The following is a description of a gene set: Any process that stops, prevents, or reduces the frequency, rate or extent of an organismal process, the processes pertinent to the function of an organism above the cellular level; includes the integrated processes of tissues and organs. Mouse Gene Set: GOBP_NEGATIVE_REGULATION_OF_MULTICELLULAR_ORGANISMAL_PROCESS species: Mus musculus, and this is the list of marker genes: Il2ra, Wnt7b, Hdac7, Furin (NCBI Gene Id 78149), Ptpn13, Pik3cb, Tfpi, Nol3, Rufy3, Rnf6, Cyp51, Adamts7, Pgam5, Tnnt1 (troponin T1, skeletal, slow), Cebpb, Abr, Hif1a, Gpr37l1, Fbln5, Fas, Actr3, Cxcl10, D130043K22Rik, Tnfaip8l2, Gp1ba, Tac1, Scgb1a1, Vash1, Gsk3a, Oprm1, Serpine2, Arg2, Adam17, Mt3, Sema4f, Nodal, Arg1, Ptgds, Tusc2, Hgs, Lilra5, Zfp423, Alms1, Hmox1, Pros1, Fgf23, Socs5, Cdh3, Nkx3-2, Mir7-1, Gpr68, Zc3h12a, Gpr55, Ltbp3 (latent transforming growth factor beta binding protein 3), Trp53, Sox11, Vtn, Hmga2, Zfp35, Tspan32, P2ry2, Inha, Dnajb11, Tek, Gpatch3 (G patch domain containing 3), Sri, Tspan8, Zfpm2, Tnfrsf13b, Cav3, Scrib, Col4a3, Apoa1, Flcn, Wnt4, Srf, Ptprc, Il20rb, Gper1, Ildr2, Reg3g, Cblb, Dip2b, Tmem98, Anxa4 (annexin A4), Prnp, Rbx1-ps, Rnf125, Prkg1, Cd276, Lilrb4b, H2-M3, Marchf7, Dab1, Il1b, Suz12, Pglyrp3, Fig4, Hdac2, Rela, Stab1, Pak1, Flt3, Cdkn2a, Hdac5, Ctla4, Jak3, Crebbp, F2rl1, Nfib, Angpt4, Extl3, Cd84, Rc3h2, Fgr, Nova1, Ctnna1, Bmp7, Fgfr3, Thy1, Ppp3ca, Nutf2-ps1, Pde3b, Ptger3, Sod1, Ager (NCBI Gene Id 11596), Cd200r1 (CD200 receptor 1), Smurf1, Psg23 (pregnancy-specific beta-1-glycoprotein 23), Tlr4, Ankrd26, Adcy7, Yy1, Irgm2, Zfp36 (zinc finger protein 36), Pdgfb, Cd59a, Ptprs, Cd300a, Fgfr1, Atg12, Kremen2, Nme2, Id2, Fbln1, Hmgb3, Met, Dact3, Ovol2, Tmem176a, Gpr174, Pglyrp2 (peptidoglycan recognition protein 2), Crhbp, Ctsc, Kcnk2, Adm, Synj2bp (synaptojanin 2 binding protein), Hoxc10 (NCBI Gene Id 209448), Nr1h2, Tnmd, Igfbp5, Lif, Wnt7a, Men1, Slamf8, Il22ra1, Cyba, Laptm5, Enpp3, Rest, Nod2, Homer3, Spx, Col4a2, Spart, Ccn4, Brca2, Enpp1, Ufd1, Xcl1, Cx3cl1, Adamts12, Thbs2, Rabgef1, Il13, Pla2g3, Spred3, Actn3 (actinin alpha 3), Arhgap4, Arrdc3, Ezr, Efemp1, Mag, Abhd6, Vsig4, Dlg5, Anxa1, Sh2b3, C5ar2, Cacnb3, Sinhcaf, Gja1, Il4, Atg5, Ezh2, Tle3, Ffar4, Stk4, Fgl2, Cd24a, Crhr2, Arrb2, Sema6a, Prdx4, Cd160, Oga, Aldh1a1, Ing1, Dbn1, Foxo1, Appl2, Tnfsf4, Bin1, Plaur, Rhbdd3, Foxc2, Anxa2, S2bpcox16, Mad1l1 (NCBI Gene Id 17120), Pth, Avp, Wnt3, C1qtnf1, Dock7 (NCBI Gene Id 67299), Rbpj, Spinkl, Akap1, Syt4, Bmpr1a, Tsc2, Jam2, Trim46, Egfr (epidermal growth factor receptor), Gpr137, Fgb, Rab11fip5, G6pdx, Zfp418, Il4i1, Trpv1, Dspp, Igf1, Hrg (histidine-rich glycoprotein), Hfe, Pthlh, Sox10, Erbb2, Proc, Tifab, Amot, Cptp, Gpr149, Pla2g2a (phospholipase A2, group IIA (platelets, synovial fluid)), Rian, Parp3, Hdac9, Aida, Adamts5, Il33, Il12b, Clec4a3, Mcc, Pax6, Wnt3a, Abcd1 (NCBI Gene Id 11666), Apoc1, Glra1, Nr1d1, Cyp19a1, Trpc2, Bglap2, Spi1, Syngap1, Oas1d, Gstp3, Lgmn, Rnls, Krit1, Sap30l, Cd86, Tgfb1, Hdac6, Apoc3, Cck, Vtcn1, Ntrk3, Ccr5, App, Il17rd, Hgf, Frzb, Ogt, Foxe3, Adora2a, Myc, Wnt11, Prickle1, Cxcr3, Gstp1, Usp2, Luc7l (NCBI Gene Id 72300), Srgn, Pik3r1, Mir98, Kcnk9, Pdcd4, Pi16, Elane, Agtr2, Zfp354c, Tnf, Klf2, Havcr2 (NCBI Gene Id 268402), Mbd1, Gata3, Ctdsp1, Gja5, Cygb, Naxe, Bmal1, Ccr1, Apln, Ddit3, Dynlt1b, Rbbp4, Lrrc32, Bcl6, Eaf2, Plcl1 (NCBI Gene Id 227120), Fgf3, Gpr35, Btg2, Parp1, Gata1, Stk11, Samsn1, Il10, Abcc8, Atp2a1, Retn, Itch, Insr, Cd38, Daam2, Mc4r, Gpr4, Nrdc, Tpsab1, Tgfbr1 (transforming growth factor, beta receptor I), Btla, Runx3, Dll1, Grem1 (gremlin 1, DAN family BMP antagonist), Wwc2, Brms1, Clec4a4, Lhx2, Chrm3, Pdcd1lg2, Hamp2 (NCBI Gene Id 66438), Npvf, Nlrc3, Cftr, Cst7, Ccr7, Nppa, Sin3a, Ifngr1, Hpgds, Dkk4, Gtf2i, Rock2, Ptpn23, Oas1h, Slc4a2, Dkk1, Hes1, Nrp1, Cbln1, Atxn2, Ins2, Traf3ip1, Hspb1, Prkca, Gbp4 (guanylate binding protein 4), Tgfb2, Sox6, Cysltr2, Mkx, Sfrp2, Epn1, Mtor, Tnfrsf4, Macir (macrophage immunometabolism regulator), Coro1c, Thoc5, Morc3, Bmp4, Arhgdib, Gpnmb, Sfmbt1, Tia1, Sdhaf2, Gnrh1, Elf4, Bmpr2, Ptprr, Lef1, Pglyrp4, Atp1a2, Ptpn11 (NCBI Gene Id 72646), Serpinb1a, Vsx2, Slc2a10, Gpr137b, Il15, Dlx1, Mycn, Nfkbid, Arid4b, Nploc4, Fstl4, Banf1, Trp63, Evl, Inpp4b, Lpin1, Tlr6, Selenos, Sox15, P2rx4, Gas6, Ticam2, Mecp2, Cntf, Snai2, Gjd3, Atp2b4, Sparc, Sirpa, Klkb1, Slc11a1, Atoh1, Fam76b, Sema4a, Tie1, Lst1, Arhgap42, Pias3, Nfkb1, Dab2ip, Slit1, Hmgb1, Adipoq, Rapgef2, Serpine1, Socs2, Nf1, Rarg, Kat5, Rarb, Tmx1, Sars1, Agt, Slamf1, Foxp4, Acp5 (NCBI Gene Id 11433), Ttr, Khsrp, Arrb1, Cers2, Crtam, Adgrb2, Grk2, Epha4, Ptk2, Siglec1 (NCBI Gene Id 20612), Pou4f2, Slfn1, Inpp5d, Nkx3-1, Cd96, Ywhah, Cx3cr1, Pdgfa, Bglap, Cldn18 (claudin 18), Nmu, Esp22, F2r (coagulation factor II thrombin receptor), Uts2r, Ada, Arhgef2, Pdcd1, Gata6, Tgfb3, Ttc3 (NCBI Gene Id 70444), Rps6ka6, Ccn6, Ihh, Trib2, Ccn3, Nrarp (NCBI Gene Id 67122), Rflnb, Prl7d1, Pax8 (paired box 8), Hmgcr, Pira1, Oas1g, Bcl11a, Tob2, Nr2e1, Lrfn5, Cxadr, Vegfa, Fbxw7 (F-box and WD-40 domain protein 7), Ryk, Nmi, Lax1, Fbn1, Isx, Zbtb7b, Pag1, Calca, C1qc (complement component 1, q subcomponent, C chain), Cd2ap, Tgfbr2, Gucy1a1, Idh2, Zc3h12d, Il23a, Otud5, Lrpap1, Sdc4, H2-T23, Epha7, Fga, Lyn, Stard13, Oprk1, Map2k5, Bcl2, Oas1c, Ppm1b, C1qtnf3, Fkbp1b, Nog, Atf2, Prkcd, Thbd, Fgl1, Abcg8, Il36rn, Tph1, Zfp683, Lingo1, Hes5, Adamts1, Tarm1 (NCBI Gene Id 245126), Prox1, Pde4d, Casz1, Ggcx, Tff2, Acvr1b, Mapkbp1, Gpr39, Id4, Prdx2, Mertk, Dll3, Klf7 (Kruppel-like transcription factor 7 (ubiquitous)), Adamts9, H2-Aa, Epn2, Slc6a4, Chsy1, Lnpep, Angpt1, Nlrp6, Tnfrsf11b, Chid1, Dtx1, Srsf6, Usp19, Ccnd2, Dusp3, Rgs2, Gstp2, Ucn2, Fgf13, Stc2, Drd2, Adtrp, Il1rl1, Plxna3, Trib1, Rac1, Drd1, Gata2, Vsir, Ppara, Rel, Ifrd1, Erfe, Tcf4, Slit2, Optc (NCBI Gene Id 269120), Adra1a, Dsg2, Klhl22, Nmnat1, Src, Nmb, Adgrb3, Dock4, Adamts18, Apoh, Akap8, Jarid2, Bcor, Ubash3b, Prkar1a, Tnr, Axl, Irgm1, Fto, Bmp10, Tbx5, Ulk1, Rara, Stat3, Runx1, Nr5a2, Clec2i, Tsku (NCBI Gene Id 244152), Gba1, Wwc1, Rgs4, Cry1, Zfpm1, Cdkn2b, Ndfip1, Tnfaip6, Nmbr, Kng2, Acvr2b, Rai1 (NCBI Gene Id 19377), Gp5, Ilrun, Npff, Loxl3, Pla2g5 (NCBI Gene Id 18784), Klf4, Ddx56, Clec4g, Plat, Ufl1, Hcrt, Ptgdr2, Clstn3, Sap130 (Sin3A associated protein), Cntnap2, Pparg, Tacstd2, Ifng, Pira12 (paired-Ig-like receptor A12), Kdm1a, Hdac1, Il12a, Sema3g, Socs1, Nlrp12, Spred2, Efna3, Pctp, Wdr77, Ccr2, Gnas, Shc1, Prdm16, Spry1 (sprouty RTK signaling antagonist 1), Socs6, Otud7b, Foxp1, Fgg, Ypel4, Nfe2, Rock1, Ecm1, Gsdma3, Cidea, Ssc5d, Ptprm (protein tyrosine phosphatase receptor type M), Alox12, Bbs2, Inhbb, Angpt2, Spsb3, Cpb2, Rgma, Cd37 (NCBI Gene Id 12493), Dpysl5, Qki, Smad4, Il4ra, Gal, Acvr1c, Nova2, Rspo2, Trem2, Ccr1l1, Suds3, Nras (NCBI Gene Id 99853), Sorl1, Milr1, Aqp4, Calcr, Napepld, Tmem119, Wnt10b, Mapk11, Stc1 (stanniocalcin 1), Clnk, Ahsg, Shh, Nlrp3, Peli1, Trak2, Nkx6-1, Adgrb1, Pla2g2f, Lgr4, Ldlrad4, Mir1a-2, Sema3a, Ski, Abcd2, Tnfaip3, Gfra4, Nos3, Cdkn1b, Kcnma1, Foxj2 (forkhead box J2), Ctnnb1, Inhba, Hhex, Rad21, Tbx21, Hhip, Vdr, Hey2, Tert (telomerase reverse transcriptase), Il18r1, Fbxo11, Kremen1, Emilin1, Mlip, Stat1, Kcnc4, Oas1f, Ripor2, Apod, Apoc2 (apolipoprotein C2), Git1 (GIT ArfGAP 1), Pdgfra, Oas1b, Ptpro, Cd9, Rc3h1, Il17d, Dcn, Sav1, Mefv, Ceacam2, Jak2, Tsc22d1, Mc1r, Sftpd, Xaf1, Wnt9b, Sox9, Vgll4, Hlx, Wnk1, Rap1gap, Yjefn3, Hspa9 (NCBI Gene Id 23909), Fbxo32, Nr1h3, Dhx58, Itgb1, Il1r2, Nckap1l, Il23r, Errfi1 (ERBB receptor feedback inhibitor 1), Cryba1, Vasn, Ido1, Foxp3, H19, Ctdp1, Kat8, Adra1d (adrenergic receptor, alpha 1d), Tnfrsf10b, Dicer1, Tlr2, Irak3, B2m, Gorasp1, Fer, Ngfr (NCBI Gene Id 18053), Spn, Efna1, Wnt9a, Calr, Pglyrp1, Lgals9, Rnf128, Il17f, Itga4, Pgk1 (NCBI Gene Id 214853), Sh2d1b1, Tafa3, Tspo, Pde5a, Sema6c, Map2k6, Gclc, Dusp22, Kctd11, Atp2b1, Pf4, Sema5a, Clec2g, Slc37a4, Prtg, Oas1a, Spag11a, Cnr1, Tnfrsf1a, Smad3 (SMAD family member 3), Muc16 (NCBI Gene Id 73732), Usf3, Tgfbr3, Tlr8, Apoa2, Prg2, Ngp, Gdf1, Bcl3, Tcf7l2 (NCBI Gene Id 21416), Atg9a, Slc12a2, Abcg5, Hsf1, F12, Esr2, Elapor2, Nos1, Ptprg, Ephb2, Hook3, Cd74, Nr5a1, Ism1, Gimap5, Fyn, Bmyc, Pten, Etv4, Foxa1 (forkhead box A1), Ulk2, Ldlr, Cyp27b1, Plcl2, Bank1, Serpinb1b, Adrb1, Spry2, Casp3, Mad2l2, Ucn, Tet1, Spink7, Homer2, Fxr1, Kifap3, Rbx1, Adora1, E2f2, Chrnb2, Minar1, Cit, Tigit, Nkx2-1, Nkx6-2 (NCBI Gene Id 14912), Gstp-ps, Adrb2, Fermt1, Tmem178, Trpm4, Smad2, Ing2, Id1, Crh, Sulf1, Apoa4, Il27ra, Chadl, Irf1, Dusp10, Rgn, Ctsg, Plac8, N4bp1, Laptm4b, Cul3, Ins1, Pcsk9, Sema6d, Trpc6, Myocd, Dlx2, Trpv3, Cdk6, Tafa5, Cuedc2, Lepr, Nlrx1, Ccl2, Procr, Nutf2, Mafb, Gata5 (NCBI Gene Id 228988), Neurog1, Hoxa7, Tnfrsf14, Pitx3, Hnf1b, Cnmd, Stk39, Smad7, Serping1, Notch1, Fuz, Tbc1d10c, Spred1, Adipor1, Sema3e, Nfatc4, Mbp, Pla2g2d, Ctsk, Trpc5, Bmp2, Cited2, Adcy10, Nr1h4, Arid4a, Igtp, Flt1, Alpk2, Nrg1, Ptgs2, Rtn4r, Fcgr2b, Sfrp1 (secreted frizzled-related protein 1), Cd274, Rheb, Abcg2, Nav3, Smad6, Il6, Apc, Gli3, Creb3l1, Prg4 (NCBI Gene Id 96875), Mtmr2, Mill1, Rag2, Npsr1, Cga, Dlk1, Mir301, Ahr, Cdh1 (NCBI Gene Id 12550), Sct, Ltf, Il22, Alox5, Rtn4, Tyro3, Lep, Bst2, Tyrobp, Vax1, Traip, Msx2, Clec2d, Ghrl, Pibf1, Cmklr1, Cd44, Fzd7, Zfp750, Crhr1 (corticotropin releasing hormone receptor 1), Ptn, Foxo4, Tac4, Ghsr, Hdac3, Serpinb1c, Osr1, Kdm4a, Ip6k1, Gdf5, Cldn5, Gdf10, Lama4, Timp1, Tmem176b, Peli3, Acot13, Lrp4, Cd200, Grn, Pilrb1, Sost, Tmprss6, Lin28a (lin-28 homolog A), Zc3h8, Zfp706, Dusp5, Phf14, C1qbp, Npy2r, Tjp2, Rps19, Rhoa, Gdi1, Hnrnpk, Twist2, Cd80, Cpe, Idua, Hamp (NCBI Gene Id 84506), Tmem131l, Nptn, Cdkl3, Tacr2, Angptl7, Ago1, F2, Fn1, Frs2, Plg, Ndrg2, Wt1, Sptbn4, Il19, Pkn1 (protein kinase N1), Lgals1, Pfn2, Mdk, Zfas1, Pml, Clec4a2, Marveld3, Efnb3, Rab11fip3, Ttc21b, Atp2a2, Foxc1, Rassf5, Fstl3, Pomc, Fshr, Rab11fip1, Pax2, Plk2, Mef2c, Oas3, Calcrl, Apom, Cartpt, Trim11, Plau, Syt11, Adra2a, Drd3, Atp1a1, Avpr1a, Adra2c, Cd36, Itga9, Tomm70a, Cactin, Tnfrsf1b, Ifnb1, Ppp1r11, Trim63, Tnfrsf21, Bcr, Adcyap1, Tfe3, Svep1, Anxa5, Apcs, Brms1l, Btk, Dock5, Ptk2b, Glmn, Lgals3, Gsk3b, Rgcc, Gli2, Sox8, Tmem53, Rnf10, Rflna (NCBI Gene Id 73121), Adgrf5, Cdk5, Erbin, Thbs4, Asmt, Npr3, Tlx2, Trim30a, Acod1, Atf4, Trh, Oas1e, Rbp4, Reg3a, Ptger4, Ybx3, Phb2, Wnk4, Mstn, Mylip, Csk, Uts2, Thbs1, Relb, Cd69, Nme1, Clec12a, Apoe, Sap30, Atm, Ntn1, Fgf8, Ptpn6, Lilrb4a, Smo, Gbp7, Irag1, Kng1, Kcnn4, Adora2b, Foxj1, Iapp, Rbbp7, Adrb3, Glrx3, Ubr5, Atf5, Rb1, Eif2ak3, G6pd2, Mmp2, Tcta, Btn2a2, Ppp2ca, Hs3st5, Sema3f, Ptpn2, Ascl2, Ccl3, Cry2, Sigirr, Apoc2l, Cul4a, Mtnr1b, Fasl, Gimap3, Mir329, Mul1, Hpn, Epha2 (Eph receptor A2), Ptch1, Ecscr, Twsg1, Mdga1, Pln, P2rx7, Lrrc17, Cebpa, Cst3, Bpi, Pawr, Cd34, Rbm10, Trim62 (NCBI Gene Id 67525), Twist1, F11, Zbtb46, Il2, Fgfr4, Lag3, Nf2, Ccl11, Acot11, Map2, Mark1, Brinp1, Ptpn22, Cnr2, Hoxa5, Stub1, Fbxo7, Zfp608, Sirt2, Cd63, Serpinf2, Psen1, Sirt1, Mfn2 (mitofusin 2), Bdnf, Wnt5a, Gata4, Trp73, Ceacam1, Dapl1, Tnfsf18, Nfkbil1, Cd83, BC037156, Lmna, Robo1, Pycard, Mepe, Gdf15, Loxl2, Abcb1a, Trim27, Dlg1, Eppk1, Stk3, Epx, Wnk3, Cbfb, Lbp, Sostdc1, Foxa2, Pcm1, Chrna7, Fxn, Pla2g10, Gadd45a, Draxin, Serpinf1, Ffar1, Gpr18, Cd300lf